Given this list of marker genes Ywhae, Rslcan18, Pkn2, Timmdc1, Sema5a, Pkp1, Il17rb (interleukin 17 receptor B), Prps2, Klf12, Zc3h6, Pcmt1 (NCBI Gene Id 97645), Cnppd1, Gk5, Birc6, Cdr2, Rpusd4, Decr1, Exoc5, Galnt7, Adcy9, Sdc1, Eif4h, Mog, Csn2, Spsb1, Tshz3, Dixdc1, Cebpb, Oacyl, Ube3a, Grm5, Tbc1d8b, Nfyc, Clint1, Hinfp, Tada2b, Gas7, Syn1 (NCBI Gene Id 20964), Adamts6, Btbd16, B4galt4, Syt4, Nap1l1 (NCBI Gene Id 53605), Arl13a, Mindy2, Nrbf2, Iqsec3, Acbd3, Fam168a, Pptc7, Zfp521, Iglon5, Hps3, Crem, Pik3cd, Gnas, Klhl2, Dach1 (dachshund family transcription factor 1), Glcci1, Arl13b, here is a description of the gene set: Mouse Gene Set: MIR_7010_3P from publication Chen Y, Wang X (PMID 31504780) Genes predicted to be targets of miRBase v22 microRNA mmu_miR_7010_3p in miRDB v6.0 with MirTarget v4 prediction scores > 80 (high confidence targets). studied in species Mus musculus